The following is a description of a gene set: Human Gene Set: GOMF_HYDROLASE_ACTIVITY_HYDROLYZING_N_GLYCOSYL_COMPOUNDS Catalysis of the hydrolysis of any N-glycosyl bond. studied in species Homo sapiens, and this is the list of marker genes: MAN2A1, RPS3, NEIL1, DNPH1, OARD1, DCTD, SMUG1, TLR2, NEIL2, IL1RAP, NEIL3, NTHL1, IL18RAP, OGG1, MAN2A2, IL1R1, ADPRH, MUTYH, IL1RL1, IL1RL2, MACROD1, IL1RAPL2, ADPRHL1 (ADP-ribosylhydrolase like 1), UNG, TLR10, IL18R1, MPG, TLR1, APEX1, SARM1, MBD4 (NCBI Gene Id 8930), IL1RAPL1, MACROD2, PCNA, TLR4, TDG, CD38, ADPRS, TLR6, BST1